Given this list of marker genes GNGT1, COL5A3, ADAMTSL5, YWHAB, SEMA5A, APBB1IP, RPL28, PIK3R3 (phosphoinositide-3-kinase regulatory subunit 3), NCBP1, CP, DNAJA2, IGLV3-16, RNMT, 8, SH3GL2 (SH3 domain containing GRB2 like 2, endophilin A1), WRN, ACE2, RNF5, IGLV2-33, RPL36AL, MEFV (MEFV innate immunity regulator, pyrin), GUSB, CSK, NELFCD, ADAMTS3, CD28, ZDHHC11, Rv3364c, HSP90AB1 (NCBI Gene Id 3326), RPL18A (NCBI Gene Id 6142), FCGR2A, PSMA2, HNRNPUL1, TRX1, CTDP1, TRAF2, US26, CD320, RPL7, MAPK14 (mitogen-activated protein kinase 14), MUC3A, UBA5, ARPC5, SPRED3, KLKB1, LTF, CFTR, TAF13, BTF3, SPCS2, HNRNPR, NAGS, P4HA2, UL11, CLINT1, hly, SFTPB, TLR1, NOTCH1, TUBA1B, ZC3HAV1, DUSP9, MIB1, IFIH1, UL5, FGF17, PIK3R4, PPP1R3C, rpoB, TENT4A, RFC4, SEH1L, RPS18, CAMK2D, macB, PTPN12, EREG, ADAMTS12, FGF1, PIK3R5, US27, CCAR1, MYO10, UL96, NFE2L2, fgd1, feoB, PRKAR2A, AKT2, rrsA, inlA, GNAI3, PSIP1, PSMB7, trxB, HBA1, CYP19A1, GANAB, CALM1, YWHAQ, ANO10, ACAN, UBA6, 1a, ALG14, FNTB, HDAC6, TGFBR1, RAP1A, NRBP1, 1B, VTN, US17, DBP, ST3GAL3, SUN2, CWC22, RPS4X, FGFR1, TNKS, GSDMD, MGAT4C (MGAT4 family member C), CDC25C, DYNLL2, GNB1, HEYL, RAC1, MAP3K7, US34, ERCC3, DOCK2, ANO9, ATG7, ITGA2B, ELOA, RAN (NCBI Gene Id 87046), RMI1, VAV2, IGKV3D-20, HLA-H, UBA52, MT2748, gspS2, ANO6, ATM, ZMYM2, SLC35D1, PDCD6IP, RPN2, CCNH, EGF, HPRT1, PRKAR1B, LAMC2, ATIC, DAD1 (defender against cell death 1), TOPBP1, RAB5C, SLC1A3, NOS2, AP2M1, FGFR1OP2, CPSF7, RPS5, PIK3CB, FUT8, tetB, RANBP1, RHOG, CDC26, XPO1, VPS18, PPFIBP1, CSPG5, PPP2R5B (protein phosphatase 2 regulatory subunit B'beta), IL1R1, F8, IGLV10-54, SPON2, FGF23, TUBA3D, ENTPD1, MGAT4B, UL18, GALNS, RAD17, TKFC (triokinase and FMN cyclase), NOXO1, ADAMTS1, RL1, IGHV3-30, ADAMTS7, KPC-2, botE, vpu, AMN, RPL23A, BTK, TRADD, gyrA, UL122, TGFA, S100A1, C3, IGLV2-14, KPNA2, CASP8, BRMS1, ZC3HC1, POMGNT1, EIF4G2, CVC1, GNG11, secA, TSC2, MYC, SEC11A, RPL35, UL9, UNC93B1, TBK1, RPL39L, UL114, MED10, PALS1 (protein associated with LIN7 1, MAGUK p55 family member), NUS1, ahpC, BCL2L1 (NCBI Gene Id 598), ABI1, EIF2AK2 (NCBI Gene Id 5610), ANO7, SLC2A9, CAST, SNF8, VPS37B, MRAS, MCL1, ARG1, PML, VPS25, MAN1B1, BTC, ARPC4, AXL, DNMT1, SHC1, KAT5, PPIG, KHK, L, RPL37, ARID4A (NCBI Gene Id 5926), IGHV3-7, SMNDC1, FDX2, IGHD, IDS, CLU, EZH2, ARPC1B, esxA, UL147A, GAA, NUP133, ADAM10, CYP1B1, DHH (desert hedgehog signaling molecule), SNRPG, IGLC7, PARP8, trx-2, RNF135, IL10, CCND1, SFTA3, RPS17, MERTK, HBB, FGF8, S100A8, MCCC2, MYO1C, G6PC3, FCGR1A, IGKV1-12, GNB4, FOXO1, XRCC6, COL4A2, RNF43 (NCBI Gene Id 54894), FMOD, CDKN2A, GNB3, HK1, UL27, POLR2J, ABL1, PPIL4, NRG1, REST, GTF2H1, NBN, CSTF1, PSMD14, IFNGR1, UL148, GP1BB, IPO7, dppF, SYMPK, rmtD, RPS19, PIK3CD, SIGMAR1, WASF3 (NCBI Gene Id 10810), bcsB, LARGE1, sapM, VPS37C, RPL27, GALK1, US33A, STAM, DERL3, DUSP7, MGAT4A, 6, POLR2B, P2RX4, ATP1B1, PHF5A, PAK2, RPL5, UL82, FXYD4, FGF7 (fibroblast growth factor 7), TAF9B (TATA-box binding protein associated factor 9b), DLL4, RHAG (Rh associated glycoprotein), CYP11B1, PARP10, CD247, PPIL6, KREMEN2, NCKAP1, NOD2, PPP2R5E, lprM, BCKDK, KAT2A, AP1B1, ha70, OS9, AUH, ISY1, GSK3A (glycogen synthase kinase 3 alpha), FAU, IGLV1-40, ABI2, TBXAS1, TAF1, MYO9B, draE, SLC33A1, RL8A, MED1, ABCD1, SSPOP, ADCY1, IGLV2-8, bamC, MMADHC (NCBI Gene Id 27249), ADCY9, TFG, CDK4, BTD (biotinidase), IGLV1-44, IRF4, botG, RPS8, CAMK2B, PSMC6, gM, RPS23, ALG11, IGHV1-69, IL1B, NCKAP1L, UL70, FXYD7, OST4, UL84, IFNA6, DBT, H2AC1, HSPA1B, CTR9, CWC25, AP2S1, RBM17, CHMP4B, BRK1, BDNF (brain derived neurotrophic factor), ELOC, PARP16, RBM22, tonB, PSMB5 (proteasome 20S subunit beta 5), CCNE2, XRN1, FMO3, FXYD3, VPS45, nleF, RPTOR, FGA, GBE1, SLC9A9, TPR (translocated promoter region, nuclear basket protein), RPL21, botA, UL146, PROS1 (NCBI Gene Id 5627), RPL8, TPMT, znuB, CBLL1, HDAC7, GOLGA7, SEL1L, 7SL RNA (ENSG00000222619), CDC25B, PSMC5, fepA, H4C1, GTF2F2, CYP2R1, POLR2C, IHH, PB1, SF3B4, HSPA8, GYS2, CASP1 (NCBI Gene Id 834), F12, IGLV2-23, SND1, PSMD8, IGHM, AHCYL1, NRAS (NCBI Gene Id 4893), GNG2, UL7, GBF1, FZD4, IGKV5-2, PSMB6, FDX1, PRPF8, PPP2R5C, HNRNPL, MLST8, RPS13, GBP4, RAE1, ALG12, 7a, RPLP0, RIPK1, GATAD2B, IGLV8-61, NFKB2, GP1BA, SLC34A1, AGO4, ARSB, EXT2, SLC67A1, MUC5B, JAG2, PRPF19, MED24, PPIB, cpnT, CHST3, TYRO3, FGFR4, TAF7, TUBA8, POLR2L, tat, GPS2, ADCY7, KDELR1, GCK, SIKE1, TAF6, POLA2, qnr, RBP4, RB1, RPS29, PCCA, exbB, MMAA, CHMP3, G3BP1, CCR5, IGLV, IGHV7-81, HDAC5, JUNB, GNAT3, MSN (moesin), LPG1G2, SLC26A4, NTF3, UL95, SLC5A1, G3BP2, bamB, STRN, FKBP4, RPS10, MAPK1, CPSF3, SEC24C, SUPT5H (SPT5 homolog, DSIF elongation factor subunit), GGCX, MC2R, SUPT16H, ADAMTS14, RPS7, KDM1A, ADAMTS15, LFNG, RPL10A, UL119/UL118, TLR7, DYNC1LI2, APRT, IGLC3, PSTPIP1, rmtF, RPIA, C4BPA, UL99, NUP153, US8, EIF4G3, PSMB1, G, NMRAL1, RFC5, MUC1, AP1M1, ADAMTS16, ERCC2, AKAP9, RAB5A, FGF20, UL91, mrcB, SNRPA1, TUBB4A, RPL6, NPIPB3, ABCG5, UL31, EXT1, lepB, DYNC1H1, TMEM258, CBX1, ITPR2, IGHG4, FXYD2, EEF1A1, LAMB2, ADCY4, CBLIF, rpoA, PRDX1, TUBB2B, LMBRD1, AQR, BCAP31, ndkA, COL5A2, oppB, NTHL1, ALG2, dlaT, LAMA5, H2BC21, PARP6, DDX20, NT5E, ALDOB, FGF19, MYD88, UVRAG (UV radiation resistance associated), CUL5, NELFB, ARPC2, CD79A, F10, UL130, JAG1, UBE2D2, NOD1, lef, ITGB1, IFNA10, OSTC, CDC73, CLDN1, FGF6, CLIP1, COL1A2, ATRX, AGRN, RPL4, BIRC6, IFNGR2 (NCBI Gene Id 3460, interferon gamma receptor 2), ACY1, yqjI, CYP4F22, RAD51B, PB2, H2BC14, UBR4, TLR6, eltB, PIK3C3, ELMO1, TAF4, TRIM27, PPIL1 (NCBI Gene Id 5482), CD9, RPLP1, CAV1, VIM, LAMA4, MED15, HSPG2, NPLOC4, ITPR1, AMER1 (APC membrane recruitment protein 1), SRSF4, NUP107, RPL3, CLEC5A, BARD1, VPS16, PSMA5, ARIH1, NLRP12, GBP2, MED13L, KIT, TIRAP, TBP, ESR2, RPLP2, WAS (WASP actin nucleation promoting factor), TUBB8, DUSP10, H2BC12, espC, CTNNBL1, MBL2, secA1, IGHV1-46, RDH5 (retinol dehydrogenase 5), MSH6, 8b, NACA, MED4, KLB, ATL2, FGF10, NRG3, CHMP2B, UPK1A, GNG4, DDX23, ybtP, CHUK, PQBP1, ARPC3, COG1, RL11, CYP11B2 (NCBI Gene Id 1585), PPP2CA, KDR, NUP205, UL111A, entS, PSMD12, GNS, UL14, CSNK1A1, ECHS1, US30, fkpA, secG, US2, IFNA1, TUBB3, CD4, APP, PPM1K, MUC13, SLC12A6, GTF2H5, NUP37, PRKX, SLC25A5, SLC6A14, PRKAR1A, SEC31A, US20, AP1S1, HNRNPA2B1, IMPDH2, VCAN, SSRP1 (structure specific recognition protein 1), NEURL1, FIP1L1, gag, SMN1, CPSF2, EPS15, CSF2RA, RPS12, MAP1B, TPST2, RHNO1, MED28, SF3B2, PAPSS1, RPL32, PPIE, PACS1, MAPK3, UFD1, CYSLTR2, CHD4, PEX19, PYCARD, TAB3 (NCBI Gene Id 257397), IGHV3-9, IGHV4-34, PDPK1, MOV10, Human respiratory syncytial virus A, COL4A4, MAN2A1, KPNA1, CHMP1A, IGKV2-30, TUBB2A, PCBP2, IRS2, SKP1, GP5, SERPING1, VAV1, IRS1, feoA, BECN1, RAB7A, ALG9, irtB, SLC37A4, SLC17A5, CHMP5, UL123, PSMD3, SF3A3, csgA, UL43, UL133, HGS, DHX15, AP2A2, ospC3, ADAMTS6, CAPNS2, fes, FGF9, MIR21, ABCC8, SYT2, TNKS2, NP, H2AC20 (H2A clustered histone 20), H2BC15, NTRK2, MUC16, HDAC4, PAH, RNPS1, ST3GAL2, MAPKAP1, STT3B, NEC2, FXYD6, PALB2, CLTC, WDR48, MAVS, US22, MUC5AC, UL36, HEY1, RELA, MUC15 (NCBI Gene Id 143662), RPS15A, GTF2B, HRAS, MPDU1, KMT2D, PDGFB, SNW1, SLC25A4, APOA1 (apolipoprotein A1), H2AC18, CHMP6, GALNT1, HDAC9, E2F3, NEIL3, CCNK, CYP26C1, GCLC, ERLEC1, RAD9A, bcsG, UL38, SLC3A1, NUP88, BUD31, XRCC5, PKLR, RPS2, SPTBN1, MMUT, PRIM1, ABCD4, CUX1, VPS4A, CDC5L, DVL3, SRSF1, BRAP, US9, efeO, GAB2, IL17A, RPS16 (NCBI Gene Id 6217), fecD, AGO1 (argonaute RISC component 1), ALK, EIF2AK3, CCNT1 (cyclin T1), UL76, 1C, POLR2K, MED29, Rv3654c, H3-3A, POLR2A, STAT2, RIR1, bamD, RBP1, BGN, MYH2, UL44, DUSP6, WIPF1, 5S rRNA, aldR, MED22, EIF4E, ADCY3, MTOR, AP1S2, IGLV3-21, UL54, DPM3, fecA, secE, FYN, UL35, SLC7A9, ENO1, BCKDHB, KREMEN1, GTF2H2, LRAT (lecithin retinol acyltransferase), FASLG, NDC1, CDC16, SNRNP200 (small nuclear ribonucleoprotein U5 subunit 200), FADD, THSD7A, mdtA, ACTG1, ha17, MUC3B, GTF2F1, 3b, FAM131B, SNRPD3, UL124, PTEN, SLC20A2, U2AF1, rmtH, VTA1, UBA3, GEMIN2, JUN, APH1B, TUBA1A, 28S rRNA, GTF2H3, UL97, UL37, OPLAH, TPM3, CDKN1B, TUBB6, RPL7A, TLR10, dppC, inlB, GTF2H4, GTF2E1, botF, MCCC1, GZMB, PAF1, CYSLTR1, GNG7, DVL1, EPCAM, FN1, rep, MED11, YBX1, QKI, RIGI, adhE2, RPL41, SNRPD2, LYN, MED18, CTSA, CBL, RPL15, Human respiratory syncytial virus A2, complete genome, UL2, FRS3, RPS26, TXNRD1, FGFR2, B4GAT1, botB, SEMA5B, iutA, US19, bfr, PPP2R5D, MASP1 (NCBI Gene Id 5648), SNRPF, PARP9, RPL10L, PSMD11, US13, IGKV2D-30, DNMT3A, NOTCH2, CDC23, MET, CEP43, SNRNP40, RPS3A, ADCY6, RPS27L, ATP6V1H, MTA2, MYH9, MUC6, MED7, RL9A, NUP43, vpr, SRD5A3, ABCA3, MED13, IGHV3-13, ADAM17, NUP54, NEDD4L, HHAT (NCBI Gene Id 55733), US3, rev, AVPR2, PEBP1, GALT, RLBP1, YWHAG, TSG101, SLC35A1, SLC2A1, SP1, RBBP4, NF1, GP9 (NCBI Gene Id 2815), ITCH, TAF5, HCK, SF3B3, DNMT3B, H2AC4, porB, tolC, HELI, TRM3, CDC27, GNG3, H2AC11, SLC2A2, TFDP2, SF3A2, SLC12A3, ABCG8, EIF4A3, IGHG3, IFNA4, H2BC17, IGHV2-5, KPNA3, ANO4, TAF4B, STAT3, IGLV3-27, ANO1, SNRPN, NELFA, E, AP2A1, H2AC14, RIPK2, SLC5A7, VPS4B, ALG3, UGT1A4, fepC, ALYREF, NUP85, LMNB1, gB, CUL3, CTSL, SUZ12, MED17, PPP2R5A, GALNT12, oppC, C1GALT1, CREBBP, TAF3, IGHV4-59, ADAMTSL3, GOLGB1, NCOR2, AVPR1A, NCSTN, ANO2, NUP214, GNGT2, IFNA2, COL4A3, UL87, PSMB3, VCP, ANTXR2, RPL22L1, HLA-G, TXNIP, CHST6, NOXA1, AKT1 (NCBI Gene Id 207), SLC40A1, ABCA1 (NCBI Gene Id 8371), UL23, RFT1, RBMX, YES1 (NCBI Gene Id 7525), SLC9A6, CLEC4M, PSMD6, ANO3, CTSG, C1QBP, UL80, EP300, ADAMTS13, yqjH, MIB2, eltA, SFTPC, BANF1, hlyB, H2AJ, SLC34A2, VWF, TCEA1 (transcription elongation factor A1), pagA, CSF2RB, MED31, mdtE, UL103, MRC1, UBE2E1, SNRPE, SMAD4, TUBB8B, MAGT1, XAB2, MAPK8, PC, IGLV1-47, FGR, ADAMTS20, CUL1, H2AX, TP53, pstS1, acrA, AGK, POLR2G, ATP1A3, ANO5, ZDHHC20, NUP160, HDLBP, RPL12, COL4A6, MAP2K7, SRSF9, LCT, RPS27, GALE, SMAD3, E2F2, RBBP7, dppA, SLC6A19, LY6E, IGKV1D-39, F11, NCK1, mrkD, PRIM2, AP1G1, gH, FGF18, MECP2, RPL37A, LAMB1, CDKN1A, CSNK2A1, MTR (NCBI Gene Id 4548), SLCO1B3, HYOU1, KLC1, RBBP5, IL6R, PTK2, IGKV1-33, dppB, BRAF, SLC7A7, JAK1, CHD3, DKK2, KPNB1, RBM5, UBC, PPM1B (protein phosphatase, Mg2+/Mn2+ dependent 1B), ELAVL2, TUBA3E, KAT2B, DENCMEMSB, MYO5A, IGKC, ST6GAL1, HSP90AA1, NRP1, FGF5, FOXO6, US34A, TRM1, UBE2S, ADAMTS8, TAOK1, CRNKL1, TRX2, KIAA1549, DOCK1, GATAD2A, GNE, 7SL RNA (ENSG00000222639), P2RX7, pp1a, RAD51, ANTXR1, EPGN, UBA1, NCAN (neurocan), ACTR2, NR3C1, FZD6, SV2A, PHF21A, CDK6, TAF12 (NCBI Gene Id 6883), ADAMTS19, SLCO2A1, HEXB, ETV6, YWHAE, VAMP1, KPNA7, SEC24A, ptpA, GEMIN5 (gem nuclear organelle associated protein 5), BRIP1, SPRED2, NTRK3, GEMIN7, SHOC2, CASP9, surA, PRDX2 (peroxiredoxin 2), KPNA5 (karyopherin subunit alpha 5), POLR2H, CD163, KIF5B, papGI, RPL27A, MLH1, MAP2K3, ST6GALNAC3, OPN1SW, IFNB1 (interferon beta 1), SLC39A4, PMM2, MDM2, ROCK2, NS5B, UL17, HDAC3, P4HA3, ZCRB1, DDOST, katG, IGLV4-60, FOXO3, U2SURP, SRSF7, UL120, MUCL1, LARP1, HDAC8, VPS37A, FGF22, IGLV7-46, SOD2, TUBB4B, IL22, SLC34A3, CSPG4, OPG199, ATRIP (NCBI Gene Id 84126), FNTA, DPM2, UL144, FDXR, MAP2K1, B4GALT7, PORCN, PSMB2, SLC4A4, BRCA2, CANX, GNAS, IRF7, US16, COL5A1, HMG20B, OAS2, PDGFA, PPIL3, SYK, POLR2F, KSR2, IRF3, SLC25A6, ZDHHC9, FASN, HSPA1A, AVP, CYBA, secA2, CRK, FZD5, ANAPC16, GPC1, 9b, MAML1, VPS11, GGT1, LAMA3, DDX42, PATJ, WASF2, sta1, CYP24A1, sta2, F2, AREG, SUPT4H1, SLC24A4, UL26, E2F1, CSTF2T, CD80, TLR5, rmtG, hbp, SLC22A5, znuC, IGHV3-53, IGF1R, DPM1, LUM, SLC35A2, LIG1, GPC6, TCF7L2, gspC2, GALNT3, TLR9, KSR1 (NCBI Gene Id 8844), NCBP2, M2-1, VPS33B, MED23, PDGFRA, GRSF1, IGHG2, GOLGA2, IVD, POLR2I, PSMA4, ST3GAL4, TUFM, RMI2, TWIST1, FBXW7, B3GLCT, GNAZ, SRSF3, PRKACB, TRAF3, CPSF1, ERLIN1, SLC2A10, AVPR1B, EEF1G, NUP188, CARS1, MUC20, HLCS, COMT, ipaH9.8, GPC4, tetA, HIP1, SBSPON, CYFIP1, UL15A, CNTRL, SFTPD, SLC36A2, RPS20, SF3B5, H2BC12L, TAF10, ITGA4, MUC21, DKK1, PARP14, GOLGA4, RL10, TAF7L, G6PC1, ARRB2, IGKV1D-16 (immunoglobulin kappa variable 1D-16), SYVN1, PTBP1, KANK1 (KN motif and ankyrin repeat domains 1), PSMC4, LCK, RCAN3, MAML3, MAMLD1, PSMC3, TICAM1, DDX3X, CUBN, TPST1, SLC6A2, KRAS, PRELP, HDAC1, chuA, CPS1, ADCY5, NEC1, AGO3, PRKAR2B, MNAT1, fyuA, CYP7B1, MAOA, Rv3655c, RAP1B, ALG8, RPL11, IFNAR2, NCL, IGHV3-33, DUSP16, PRCC, HES5, POLR2E, FZD7, PPE2, ITGB3, ARF1 (NCBI Gene Id 375), PRKG1, ATP1A4, SDC1, DLL1, IGLV1-36, PA, KITLG, UBE2C, PCBP1, ATP1B3, LMNA, IKBKB, ROCK1, blaSHV-12, RANBP2, C4A, TGFBR2 (transforming growth factor beta receptor 2), TUSC3, CPSF4, UL34, RPL36, OGN, ADAMTS2 (NCBI Gene Id 9509), TPM4, U2AF1L4, ADAMTS4, CNKSR2 (connector enhancer of kinase suppressor of Ras 2), TXNL4A, PSMB4, SRSF2, VCL, BAIAP2, SLC27A4, ahpE, ADAMTS9, WIPF3, B4GALT1, LY96, IDUA, MAP3K11, CDH1, TMPRSS2, ANAPC5, KDM7A, sodB, ERBB2, DAXX, SGSH, efeB, PIK3CG, CASP4, TLR3, MED19, RPS28, GNAI1, ERBB4, hlyE, THBS1, ELK1, DVL2, IGHV1-2, SCAP, SDC4, PSMD1, ALG6, UL79, PDIA3, RPS6, PSENEN, GEMIN6, RCOR1, GNB2, gag-pol, UBB, PCF11, TUBAL3, IGLV7-43, EPM2A, DCN, DAG1, IGLV5-37, degP, H2AC25, cya, MASP2, PRKG2, POMT2 (NCBI Gene Id 29954), TJP1, HEY2 (hes related family bHLH transcription factor with YRPW motif 2), GTF2A2, CSTF2, SFTPA1, IFNA16 (interferon alpha 16), POMT1, VPS33A, ADRM1, UL69, S100A9 (NCBI Gene Id 6280), WDR33, STAT5A, ADAMTSL4, PPP1CC, N, znuA, ANO8, FXR1, SFTPA2, ALG13, IL10RA, CREB1, CLP1, MAPK9 (NCBI Gene Id 5601), TIMD4, TUBA4A, RAB5B (RAB5B, member RAS oncogene family), acrD, RBPJ, WASL, UBE2D1, UL92, DNAJC8, RBM10, CWC27, H2BC13, RPL31, HDAC11, esxH, NFKBIA, TUBB (tubulin beta class I), HBEGF, MCP, CDK19, UL4, IGLV3-25, MLKL, CD14, EXOC1, SF3A1, FOXO4, PRMT1, NMI, NUP155, SLC12A1, WNT3A, PRPF6, GNG5, NHERF4, PDCD1, GAS6, CALM3, NCKIPSD, FKBP1A, IGHV3-23, DHX38, emrE, sodC, RAD51D, CALM2, IGLV1-51, SAP30, PAPOLA, FCGR3A, IGKV1D-33, DHX16, ADAMTSL1, PLCG1 (phospholipase C gamma 1), PSMC2, DHDDS, TAB2, SCP, MVB12A, BTRC, SH, SPON1, UL22A, CORO1A (coronin 1A), IL1A, fhuC, M2-2, IFNA17, IQGAP1, RPS24, FGF4, CD2BP2, H2BC5, SYT1, POLA1, FRS2, TUBA1C, B2M, IGKV1-39, MED14, env, LAMC3 (laminin subunit gamma 3), UL131A, IFNA7, POMC, RETREG1, TLR2, RFC2, AAAS, ADAMTS5, TBL1X (NCBI Gene Id 6907), ANAPC7, MARK3, CYP26B1, TRAK1, HSPA5, SRPK1, TGFB1, SLC24A5, IKBKE, MAP1LC3B, ABCA12, MED25 (NCBI Gene Id 81857), HNRNPF, CDK2, TBL1XR1, C1S, PMS2, GPC5, GNAI2, SLC16A1, SQSTM1, SOS1, KCNJ11, PROC, ACAT1, GBP3, GSDME, UL21A, ANAPC11, US28, MUC17, NUP93 (nucleoporin 93), MED8, US32, IL17F, IGLV4-3, H2AC6, OPN1MW, VHL, F, PSMA1, THSD1, AGTRAP, IGKV2D-28, TRIM24, BSG, CYP2U1, CTNND1, CD300A, AGO2, MED20, SPCS3, RPSA, TAF2, SLCO1B1, FZD8, PSMC1, RPS4Y2, RAD9B, GRPEL1, TAF11, RPL24, UL102, secF, CCNB1, CSTF3, MED21, BAG2, FGF2, HAVCR1, UBE2I, CRBN, AGGF1, pef, RPL13A, CX3CR1, H2BC18, ACTB, gyrB, IGKV3-15, SLC26A2, HLA-F, US12, LRRFIP1, ADA, RTN3, PUF60, STT3A, ABCA4, RBBP8, GALM, C4B, PRKACA, C1QA, RPA3, ABCB4, MMP9, CTBP1, sta3, DYNLL1, msrA, SH3GL1, eis, CDC25A, PGM1, PLK2, PSMA6, TUBA4B, ntnha, GSK3B, TNRC6C, GCC2, ENTPD5, MTRR, Hh5 strain Merlin complete genome, MGAT1, RRBP1, oppA, RPS11, DDX46, ATP1A2, CDK5, FGF16, KL, YWHAH, WNT5A, UL121, SI, CD33, NOTCH3, EGFR, TTR, DKK4, ABCC9, PCCB, ESRP1 (NCBI Gene Id 54845), EIF4E3, IGKV2-28, DLD, SAP30L, efeU, ISCU, H2AC7, ST6GALNAC2, CD36, TAL1, VEGFA, UL138, RPS4Y1, MMAB, BRCA1, FGG, ATG14, BCAN, AP1M2, SDC2, ABCC6, CPSF6, SPRED1, oqxA, RCC1, dsbA, GYG2 (glycogenin 2), SLC3A2, POM121, ARAF, fepB, SFPQ, OTC, ERLIN2, RNF185, HNRNPU, RTF1, UL147, NA, LEO1, MED9, DPEP2, AUP1, UL48, LMO7, ggtA, RPL14, MAT1A, MAP2K2, LAMB3, H2BC9, hlyD, PSMD2, EML4, lpdC, MED27, LIG4, FURIN, RPL39, CSNK2B, bcsC, CDK5R1 (NCBI Gene Id 8851), IGLC2, AXIN1, ZDHHC5, F9, ZFYVE9, IRAK1, MOGS, BRD4, NFKB1, THSD4, ZBP1 (Z-DNA binding protein 1), trxA, ITPR3, TRS1, M, VPS41, MED12, UL13, CAPNS1, VPS37D, CDK7, PPP2R1B, ARRB1, GGT5, SNAP25, PTPN6, FLT3, CAMK2G, HNRNPD, mdtB, SLC1A1, ELOB, SF3B6, hlyA, YWHAZ, HNRNPA0, CDK9, rmtC, IGKV1-5, CAPN2, fhuB, RAD51AP1, AKT3, MGAT5, UBE2V1, FEN1, CTNNB1, HLA-A, B3GALT6, SLC11A2, TALDO1, UL117, TAF8, AP1S3, TOMM70, IGHV, DNAJC3, APC, SH3KBP1, SLC25A15 (NCBI Gene Id 3089), PIK3CA, TAB1, WIPF2, UL78, GTF2A1, RPA2 (replication protein A2), NEK2, CNBP, TUBA3C, CDC40, fhuD, fecC, JAK2, HNRNPH2, PABPC1, glbN, SEC11C, UGT1A1, HNRNPM, VPS39, SLC6A5, GCKR, exbD, SUMO1, NUDT21, RPS6KB2, LAMA1, SLC5A2, IFNAR1, GBP1, FLT3LG, NEURL1B, HGF, RPL30, IL17RA, UL88, TRAT1, skp, PPP1CA, PLRG1 (pleiotropic regulator 1), TRIM4, HNRNPC, PSMA3, SLC5A5, CAMK2A, ZAP70, TAF1L, NOX4, RPL10, ISG15, CLTA, SEC24B, PSEN1 (NCBI Gene Id 5663), CYP27A1, SPCS1 (NCBI Gene Id 94556), ADORA2B, H2AC12, IGKV3-11, LRP6, CYP27B1, RNA4.9, FOXM1, VAMP2, MAPRE3, H2AB1, AAC(6')-Ib, UBE2L6, CD86, RPL26, HNRNPA1, rpoC, AP2B1, MAP2K6, ESR1, UL83, RPS15, NOTCH4, HEPH, RUNX1, STX1A (NCBI Gene Id 6804), US11, LAMC1, RHBDF2, STRA6, CALR, PRKACG, HEXA, KPNA4, fepG, PLCG2, ACOT2 (acyl-CoA thioesterase 2), CCNE1, XRCC2, IL17RC, IGKV2D-40, HDAC10, CHMP4C, DCXR, PIK3AP1, DPAGT1, COL1A1, SEC23A, SEM1, PRR5, NAGLU, STAT5B (NCBI Gene Id 6777), UL16, GSS, CD19, OPN1LW, MVB12B, UL47, COL4A1, MSH3, TFDP1, IGKV1D-12, EFTUD2, LAMA2 (laminin subunit alpha 2), IDH1, PPIA, US14, IGHV3-11, RPA1, ASH2L, CGAS, RPL35A, NEIL1, SNRPB, RPL23, BLM, TAF15, MED6, CYP17A1, ADAMTS18, IGHV2-70, IFNA21, FGF3, OMD, TRIM25, PDGFRB, UL32, RPL18, acrB, ARID4B, yhjR, MGAT2, IGLV6-57, NUP42, ELMO2, DCTN1, RPL38, ERBB3, IGLV2-18, US24, PGK1, THBS2 (NCBI Gene Id 7058), RPL26L1, ZDHHC3, SNRPB2, SV2C, TRIM28, PSMD7, 18S rRNA, ATP1A1, SRC, S, DERL1, DPY30, SLC6A3, 16S rRNA, IL6, Rv2895c, TLN1, SUGP1 (NCBI Gene Id 57794), RAD51C, ST3GAL1, DNAJB11, SRRT, RNF213, armA, NRG4, HLA-B, CNKSR1, ALG1, RAD50, IGKV1-17, CVC2, APOBEC3G, CHMP7, gN, NRG2, CAPN1, rpoZ, BCAS2, U2AF2, RPS9, H2BC11, CDK8, vif, EED, GNG12, SLC4A1 (solute carrier family 4 member 1 (Diego blood group)), RANGAP1, NUP62, BAG4, MUC2, UL24, ANAPC15, C1GALT1C1, UL98, mip, MED30, ELL, mdtC, bfrB, DYNLT1, FGB, RNGTT, RNASEK, CAMK4, SLC17A8, MTA3, SRPK2, bcsA, NLRP3, SLC29A3, CHMP4A, UL112/UL113, GNG13, SEC13, RDH12, VAV3, ST6GALNAC4, MRE11, COL4A5, SHH, CD8B, MUC4, CEBPB, US23, NAPEPLD, UL29, HUS1, IGLV5-45, BCR (BCR activator of RhoGEF and GTPase), VPS36, CHMP2A, TRM2, H2BC3, fecB, H2BC1, UL132, SFN (stratifin), PARP4, GUCY2C, ABCB6, fecE, BST2, BCL2L11, UBAP1, NTF4, mppA, IGLV3-19, GTF2E2, HLA-C, IGKV2-29, SH3GL3, AP3B1, EIF4A2, UL71, HMGA1, CRB3, SLC35A3, RFC3, C3AR1, SLC26A3, ZDHHC2, UBA7, fimH, HNRNPK, MUTYH, IGKV3-20, SLC6A20, ELOA2, THSD7B, ADAMTS10, GEMIN8, CCND2, BLNK, FUS, ATP1B2, SRSF6, CCNC, FXYD1, GYG1, CEBPD, SRSF5, UL74, US10, P4HA1, BCKDHA, CTBP2, HDAC2, B3GAT3, TYK2, PIK3R2, XRCC4, IGHG1, Rv1410c, FAM114A2, fepD, RAF1, IRAK4, BCL2A1, KEAP1, bcsQ, PPP1CB, KERA, CD209, ANAPC4, GNG10, CCNT2, SEC24D, HES1, RPL19, HLA-E, CHSY1, RPL17, SUGT1, PABPN1, NPM1, IGLV3-22, PIK3R6, H3C1, BIN2, RPS3, PSMD13, mdfA, SAP18 (Sin3A associated protein 18), HYAL1, WDCP, SF3B1, DNA2, ANAPC1, AKT1S1, PPP2R1A, IGLV3-12, GBP6, RPS27A, CYP11A1, MSH2, POM121C, tetX, DHX9 (NCBI Gene Id 3450), ICOS, MUC7, NOX1, MPI, SKP2, RAD1, HNRNPH1, GPKOW, GNB5, lprG, bamA, ADCY8, DYNC1I2, RICTOR, HERC5, GNG8, SLC35C1, EIF4G1, ANAPC2, UL94, NUP50, FZR1, NS, UL52, CWC15, STX1B, SUDS3, SRSF11, H2BC26, EDEM2, CXCR4 (NCBI Gene Id 93405), HA, P, IKBKG, 5.8S rRNA, SRRM2 (serine/arginine repetitive matrix 2), STAT1 (signal transducer and activator of transcription 1), GFPT1, ANAPC10, UBE2N, GCLM, SARS coronavirus, complete genome, PPIH, secD, FGFR3, MPRIP, NUP58, BCL11A, SAR1B, CDC37, SV2B, dppD, DPEP1, SNRPD1, ADCY2, ADAMTSL2, CHST14, IL18, NCOR1, nef, ABCC2, WBP11, secY, DDX5, PSEN2, bla, IFNA14, SRRM1, PSMA7, SKIC8, TLR4, OGG1, IMPDH1, H2AC21 (H2A clustered histone 21), RPN1, H2BC4, HNRNPA3, RPL9, GYS1, GEMIN4, UTI89_C2180, TXN, CYFIP2, MYO18A (NCBI Gene Id 9799), RPL22, UL25, ASL, bamE, RIPK3, CD79B, oppD, NFKBIB, SDC3, STAM2, irtA, CDKN1C, PAPSS2, esxG, CLCN6, GJA1, DUSP8, US18, macA, UL41A, SMAD2, IGLV2-11, CDC42, MUC19, PIM1, ELAVL1, ZDHHC8, TOP3A, NELFE, APH1A, NUP35, DYNC1I1, VPS28 (NCBI Gene Id 51160), ATR, sfaS, DERL2, ASS1, H3C15, ahpD, PARP1, gL, MBD3, HA-33, PNP (NCBI Gene Id 4860), 3a, GAB1 (GRB2 associated binding protein 1), TUBB1, UL104, IGLV4-69 (immunoglobulin lambda variable 4-69), MMACHC, ADAMTS17, NUP98, EXO1, RPL13, JAK3, ACTR3, MAP2K4, WASF1, NMT2, NHLRC1, AHCY, rmtB, RPS25, PIK3R1, POLR2D, P4HB, TAF9, fliC, tpx, IGLC1, ARPC1A, RPL34, gdx, IPO5, SLC24A1, SIN3A, WDR5, DUT, TRIP11, NMT1, STING1, MED26, IGLV3-1, GRB2, CHERP, PRF1, IGKV4-1, MUC12, RPL36A, GPC3, bcsE, DOLK, SERPINE1, EEF2 (NCBI Gene Id 408221), mdtF, IGKV1-16, CCND3 (cyclin D3), HIBCH, HMOX1, SLC22A12, C4BPB, TCN2, PTPN11, H2AZ2, PPP2CB, GLB1, PRKCSH, BAD, RPS21, CFP, ERBIN, IGLC6, ACACA, NR4A1, TLR8 (NCBI Gene Id 92553), RBX1, F5, RPL3L, NEU1, IRAK2, MTA1 (NCBI Gene Id 9112), gspD2, GPC2, RPL29, DYNC1LI1, IFNA8, NUP210, CD3G, IGLV11-55 (immunoglobulin lambda variable 11-55 (non-functional)), EIF4A1, DNAJC10, IGHV4-39, S1PR1 (sphingosine-1-phosphate receptor 1), LRP5, PHB1, CSNK2A2, MAML2, HMGB1, IGHV3-48, RAC2, RPS14, MED16, HGSNAT, CYP21A2, botD, EMC4, PTGES3, ABCB11, IFNA5, TRAF6, here is a description of the gene set: studied in species Homo sapiens From this molecular viewpoint, human disease pathways have three mechanistic causes: the inclusion of microbially-expressed proteins, altered functions of human proteins, or changed expression levels of otherwise functionally normal human proteins.<p>The first group encompasses the infectious diseases such as influenza, tuberculosis and HIV infection. The second group involves human proteins modified either by a mutation or by an abnormal post-translational event that produces an aberrant protein with a novel function. The existence of variant proteins and their association with disease-specific biological processes is represented by inclusion of the modified protein in a new or variant reaction, an extension to the 'normal' pathway. Diseases which result from proteins performing their normal functions but at abnormal rates can also be captured, though less directly. Many mutant alleles encode proteins that retain their normal functions but have abnormal stabilities or catalytic efficiencies, leading to normal reactions that proceed to abnormal extents. Reactome Pathway: Disease